The following is a description of a gene set: from publication Chen Y, Wang X (PMID 31504780) Genes predicted to be targets of miRBase v22 microRNA hsa-miR-6736-3p in miRDB v6.0 with MirTarget v4 prediction scores > 80 (high confidence targets). studied in species Homo sapiens Human Gene Set: MIR6736_3P, and this is the list of marker genes: HECW1, KCTD7, PLXNA4, DDX49, HSPB8, NEK9, FAN1, VCL, DRICH1, GRK3, NFATC1, MAP2K3 (NCBI Gene Id 92079), KLHDC3, HSF5, CLEC4G, UGT1A10, MICAL2, ENDOD1, DMC1, DOCK11, RXYLT1, PIKFYVE, UGT1A8, CELF4 (CUGBP Elav-like family member 4), IP6K2, COMMD5, ACVR2A, DLGAP1, ZNF609, AP1G1, KCTD5, KCNIP2, MED29, MNAT1, CD6, STMN4, ABR, AGO1, NPTX1, PCTP, PDE7B, TSPAN5, RAB5IF, TBC1D22B, STAT3, LDHA (NCBI Gene Id 3939), UGT1A3, CCNF, FAM234A, PIEZO2, ZFYVE27, PDE1C, RYBP, BEAN1, MTSS2, PIK3C2A, CUEDC1, KLHDC7A, RNF183, GIMAP1, JPH1 (NCBI Gene Id 56704), FAM78B, HTT, PLA2G4C, TRDMT1, SPDYE2, UGT1A5, PLP1, ZZZ3, MAPK11, DNPEP, DDX56, MRPL57, KDM4A, PHF8, INAVA, RGS16, DCTN5, MIEF2, RSBN1L, SPDYE2B, EIF4E, MTMR4, NECTIN1 (NCBI Gene Id 84853), MED14, KCNB1 (NCBI Gene Id 3745), UGT1A1, UGT1A7, BTRC, AOX1, RANBP9, SLC12A8, CPEB2 (cytoplasmic polyadenylation element binding protein 2), TRIM25, PPCDC, CYTH2 (cytohesin 2), UBE2QL1, STRA6, NRP1, MFSD13A, PPP1R14C, PAK1, UGT1A4, BTN2A2 (butyrophilin subfamily 2 member A2), HYCC2, MBD6, ZNF250, SPDYE5, EEF1AKMT3, TMEM243, SP4, ZNF384, HNRNPH1, ALDH5A1, SPDYE1, DNAJC3, NSUN2, SPDYE6, IL17RD, UGT1A9, GRHL2, ZNFX1, CYB561, APOL3, SLC25A36, UGT1A6, DCHS1, CD34, TRIB2